Given this list of marker genes LRCH4, ZEB1, IFT46, LOXL1, NRP1, RSRP1, ACKR4, ACAA2, PFKM, PPIE, SDHAF1, CD28, NR1H2, KRAS, NFKBIA, CLK2, UBC, SNAI2, PITPNB, TMEM230, MCL1, ARF5, SOX1, KCNJ2, GZMM, SSBP2, NONO, SMC4 (NCBI Gene Id 10593), SYT2, DMBT1, MAK, ATP6V0A2, SLC1A2, ICAM2, DVL2, BACH1, ACTB, VWF, here is a description of the gene set: from publication Hu T, Gibson DP, Carr GJ, Torontali SM, Tiesman JP, Chaney JG, Aardema MJ (PMID 15120960) Human Gene Set: HU_GENOTOXIN_ACTION_DIRECT_VS_INDIRECT_4HR studied in species Mus musculus Genes discriminating between direct (cisplatin, MMS, mitomycin C) and indirect (paclitaxel, hydroxyurea, etoposide) acting genotoxins at 4 h time point. During the safety evaluation process of new drugs and chemicals, a battery of genotoxicity tests is conducted starting with in vitro genotoxicity assays. Obtaining positive results in in vitro genotoxicity tests is not uncommon. Follow-up studies to determine the biological relevance of positive genotoxicity results are costly, time consuming, and utilize animals. More efficient methods, especially for identifying a putative mode of action like an indirect mechanism of genotoxicity (where DNA molecules are not the initial primary targets), would greatly improve the risk assessment for genotoxins. To this end, we are participating in an International Life Sciences Institute (ILSI) project involving studies of gene expression changes caused by model genotoxins. The purpose of the work is to evaluate gene expression tools in general, and specifically for discriminating genotoxins that are direct-acting from indirect-acting. Our lab has evaluated gene expression changes as well as micronuclei (MN) in L5178Y TK(+/-) mouse lymphoma cells treated with six compounds. Direct-acting genotoxins (where DNA is the initial primary target) that were evaluated included the DNA crosslinking agents, mitomycin C (MMC) and cisplatin (CIS), and an alkylating agent, methyl methanesulfonate (MMS). Indirect-acting genotoxins included hydroxyurea (HU), a ribonucleotide reductase inhibitor, taxol (TXL), a microtubule inhibitor, and etoposide (ETOP), a DNA topoisomerase II inhibitor. Microarray gene expression analysis was conducted using Affymetrix mouse oligonucleotide arrays on RNA samples derived from cells which were harvested immediately after the 4 h chemical treatment, and 20 h after the 4 h chemical treatment. The evaluation of these experimental results yields evidence of differentially regulated genes at both 4 and 24 h time points that appear to have discriminating power for direct versus indirect genotoxins, and therefore may serve as a fingerprint for classifying chemicals when their mechanism of action is unknown.